Given this list of marker genes Dtymk, Cad, Ak9, Entpd4, Entpd7, Entpd5, Cmpk2, Entpd4b (ectonucleoside triphosphate diphosphohydrolase 4B), Cmpk1, Dhodh, Umps, here is a description of the gene set: The chemical reactions and pathways involving pyrimidine nucleoside diphosphate, a compound consisting of a pyrimidine base linked to a ribose or deoxyribose sugar esterified with diphosphate on the sugar. studied in species Mus musculus Mouse Gene Set: GOBP_PYRIMIDINE_NUCLEOSIDE_DIPHOSPHATE_METABOLIC_PROCESS